Given this list of marker genes RAP1A, YWHAB, NGF, MAP2K1, RAPGEF1, FRS2, CRKL, MAP2K2, NTRK1, MAPK3 (mitogen-activated protein kinase 3), MAPK1, BRAF, here is a description of the gene set: The adaptor protein Frs2 (Fibroblast growth factor receptor substrate 2) can mediate the prolonged activation of the MAPK (ERK) cascade. Reactome Pathway: Frs2-mediated activation species: Homo sapiens part of: Prolonged ERK activation events